Given this list of marker genes MELK, TACC3 (NCBI Gene Id 10460), POU3F1, POU3F2, PCDH18, MYH8, CDC20, HES5, CCNB1, FGFR4, INKA2, POU3F3, ANLN, MASTL (microtubule associated serine/threonine kinase like), ASPM, PLP1, TM7SF2, KIF23, PTPRN, SOX21, TK1, SFRP1, S1PR1, NOTCH2, BIRC5, HLX, HMGA1, MDK, NR2F1, PHF20L1, ARID5B, C17orf49 (NCBI Gene Id 124944), PARPBP, PRR11, TTN, MKI67, KRT2, TNXB, NUMA1, HEY1, KIF11, RTKN, TPX2, AURKB, NDE1, GOLGB1, PRC1, KIF14, ASCL1, SLX1B, CTSL (NCBI Gene Id 1514), DDX17, NOVA2, CKAP2, SOX11, GPSM1, ATP1A1, LHX1, DBX1, CDK1, CDC14B, BMS1, TOX3, CDCA2, MT2A, OTP, PPP1R3G, FBXO5, TTK, CDCA3, ELAVL4, UCP2, DLGAP5, CCNB3 (cyclin B3), FOXM1, GTSE1, here is a description of the gene set: Human Gene Set: SHEPARD_BMYB_TARGETS from publication Shepard JL, Amatruda JF, Stern HM, Subramanian A, Finkelstein D, Ziai J, Finley KR, Pfaff KL, Hersey C, Zhou Y, Barut B, Freedman M, Lee C, Spitsbergen J, Neuberg D, Weber G, Golub TR, Glickman JN, Kutok JL, Aster JC, Zon LI (PMID 16150706) species: Homo sapiens Human orthologs of BMYB target genes in zebra fish, identified as commonly changed in the BMYB loss of function mutant crb ('crush and burn') and after knockdown of BMYB by morpholino. A major goal of cancer research has been to identify genes that contribute to cancer formation. The similar pathology between zebrafish and human tumors, as well as the past success of large-scale genetic screens in uncovering human disease genes, makes zebrafish an ideal system in which to find such new genes. Here, we show that a zebrafish forward genetic screen uncovered multiple cell proliferation mutants including one mutant, crash&burn (crb), that represents a loss-of-function mutation in bmyb, a transcriptional regulator and member of a putative proto-oncogene family. crb mutant embryos have defects in mitotic progression and spindle formation, and exhibit genome instability. Regulation of cyclin B levels by bmyb appears to be the mechanism of mitotic accumulation in crb. Carcinogenesis studies reveal increased cancer susceptibility in adult crb heterozygotes. Gene-expression signatures associated with loss of bmyb in zebrafish are also correlated with conserved signatures in human tumor samples, and down-regulation of the B-myb signature genes is associated with retention of p53 function. Our findings show that zebrafish screens can uncover cancer pathways, and demonstrate that loss of function of bmyb is associated with cancer.